The following is a description of a gene set: Human Gene Set: SIMBULAN_UV_RESPONSE_NORMAL_DN Solar ultraviolet B (UVB) acts as both an initiator and promoter in models of multistage skin carcinogenesis. We found that, whereas UVB induces apoptosis in human papillomavirus-16 E6/7-immortalized keratinocytes, it inhibits markers of differentiation in human foreskin keratinocytes (HFK). Potential mechanisms for this differential response were examined by DNA microarray, which revealed that UVB alters the expression of three of the four human inhibitor of differentiation/DNA binding (Id) proteins that comprise a class of helix-loop-helix family of transcription factors involved in proliferation, differentiation, apoptosis, and carcinogenesis. These results were verified by RT-PCR and immunoblot analysis of control and UVB-irradiated primary and immortalized keratinocytes. Whereas Id1 was downregulated in both cell types, Id2 expression was upregulated in primary HFK, but not immortalized cells. In contrast, Id3 expression was significantly increased only in immortalized cells. The differential expression pattern of Id2 in response to UVB was recapitulated in reporter constructs containing the 5' regulatory regions of this gene. Id2 promoter activity increased in response to UVB in HFK, but not in immortalized cells. To identify the regulatory elements in the Id2 promoter that mediate transcriptional activation by UVB in HFK, promoter deletion/mutation analysis was performed. Deletion analysis revealed that transactivation involves a 166 bp region immediately upstream to the Id2 transcriptional start site and is independent of c-Myc. The consensus E twenty-six (ETS) binding site at -120 appears to mediate UVB transcriptional activation of Id2 because point mutations at this site completely abrogated this response. Chromatin immunoprecipitation and electrophoretic mobility-shift assays verified that the Id2 promoter interacts with known Id2 promoter (ETS) binding factors Erg1/2 and Fli1, but not with c-Myc; and this interaction is enhanced after UVB exposure. Similar to the effects of UVB exposure, ectopic expression of Id2 protein in primary HFK resulted in inhibition of differentiation, as shown by decreased levels of the terminal differentiation marker keratin K1 and inhibition of involucrin crosslinking. Reduction of Id2 expression by small interfering RNAs attenuated the UVB-induced inhibition of differentiation in these cells. These results suggest that UVB-induced inhibition of differentiation of primary HFK is at least, in part, due to the upregulation of Id2, and that upregulation of Id2 by UVB might predispose keratinocytes to carcinogenesis by preventing their normal differentiation program. Genes down-regulated in HFK cells (primary keratinocytes) in response to UVB irradiation. from publication Simbulan-Rosenthal CM, Trabosh V, Velarde A, Chou FP, Daher A, Tenzin F, Tokino T, Rosenthal DS (PMID 16007217) species: Homo sapiens, and this is the list of marker genes: ITGA6, VEGFA, CCNF, FAT2, ITGB4, POLR2A, AHNAK, ADRB2, RBPMS, MCL1, CDH1, THBS1, GADD45B (growth arrest and DNA damage inducible beta), ID1, EGFR, PLEC, GRB7, TP63, MN1, DUSP7, TACC1, PTP4A1, CNBP, ENC1, MARCKS, SF3A2, HAS2, PIP4K2B (phosphatidylinositol-5-phosphate 4-kinase type 2 beta), EMP1, PHLDA1, PRRC2C, MYC, RBMS1